The following is a description of a gene set: Genes down-regulated in double positive thymocytes: wildtype versus over-expressing HDAC7 fused with VP16. from publication Kasler HG, Young BD, Mottet D, Lim HW, Collins AM, Olson EN, Verdin E (PMID 21398603) Human Gene Set: GSE26488_WT_VS_VP16_TRANSGENIC_HDAC7_KO_DOUBLE_POSITIVE_THYMOCYTE_DN species: Homo sapiens Abstract of publicaton: CD4/CD8 double-positive (DP) thymocytes express the transcriptional repressor Histone Deacetylase 7 (HDAC7), a class IIa HDAC that is exported from the cell nucleus after T cell receptor (TCR) engagement. Through signal-dependent nuclear export, class IIa HDACs such as HDAC7 mediate signal-dependent changes in gene expression that are important to developmental fate decisions in multiple tissues. We report that HDAC7 is exported from the cell nucleus during positive selection in thymocytes, and regulates genes mediating the coupling between TCR engagement and downstream events that determine cell survival. Thymocytes lacking HDAC7 are inefficiently positively selected due to a severely shortened lifespan and exhibit a truncated repertoire of TCR Jalpha segments. The expression of multiple important mediators and modulators of the response to TCR engagement is altered in HDAC7-deficient thymocytes, resulting in increased tonic MAP kinase activity that contributes to the observed loss of viability. Remarkably, the activity of Protein Kinase D, the kinase that mediates nuclear export of HDAC7 in response to TCR signaling, is also increased in HDAC7-deficient thymocytes, suggesting that HDAC7 nuclear export governs a self-sustaining auto-excitatory loop. These experiments add to the understanding of the life/death decision in thymic T cell development, define a novel function for class IIa HDACs, and point to a novel feed-forward mechanism whereby these molecules regulate their own state and mediate stable developmental transitions. Title of manuscript: Nuclear Export of Histone Deacetylase 7 During Thymic Selection Mediates Immune Self-tolerance. abstract of manuscript: Histone Deacetylase 7 (HDAC7) is a TCR signal-dependent regulator of differentiation that is highly expressed in CD4/CD8 double-positive (DP) thymocytes. Here we examine the effect of blocking TCR-dependent nuclear export of HDAC7 during thymic selection, through expression of a signal-resistant mutant of HDAC7 (HDAC7-delta-P) in thymocytes. We find that HDAC7-delta-P Transgenic thymocytes exhibit a profound block in negative thymic selection, but can still undergo positive selection, resulting in the escape of autoreactive T cells into the periphery. Gene expression profiling reveals a comprehensive suppression of the negative selection-associated gene expression program in DP thymocytes, associated with a defect in the activation of MAP kinase pathways by TCR signals. The consequence of this block in vivo is a lethal autoimmune syndrome involving the exocrine pancreas and other abdominal organs. These experiments establish a novel molecular model of autoimmunity and cast new light on the relationship between thymic selection and immune self-tolerance. Goal of Microarray experiment: We did these experiments to determine how alteration of the function of HDAC7, a site-specific and signal-dependent repressor of transcription, changes gene expression in CD4/CD8 DP thymocytes., and this is the list of marker genes: CYB561A3, ERO1A, GRN, SPNS3, ABHD5 (NCBI Gene Id 51099), CDC42BPB, OBI1, S1PR3, LAX1, MAP2K1, BID, ACKR2, TGFBR1, PDE4D, BZW2, GPR156, PIP4K2A, DTX1, LY96, HCK, NEBL, MYL4, ATF6, RPS4X, PA2G4, SIRPA, TMEM154, NCBP1, CD274, FTO, RPS9, FBXL5, CYP39A1, RXFP1, FCRL5, DPH5, SORBS2, ACKR3, UTRN, ATXN1, RNF145, QDPR, BMP2K, PLAC8, GM2A, CTSC, RPL36A, PLXNC1, RPL24, RPL32, THADA, DUSP16, RPS5, LDLRAD3 (NCBI Gene Id 143458), CACNA1E, HERC3 (NCBI Gene Id 9838), MYOF, SERPINE2, CAPN2, TRPS1, COQ8A, SLC25A4, LY6S, CR2, CD38, TBC1D9, NDST1, DNAJC3, TBL1XR1, MS4A7, SCARNA17, CARMIL1, LYNX1, NAE1, TRIM7, RPL37A, PDE8A, ABR, ST3GAL2, ZMAT4, GNS, MICU3, CYBB, CSF2RB, IL9R, CD300LF, UBE2R2, TAF1D, RPL13, MARCKS, RUNDC3B, ARHGEF12, BCAP29, BLNK, MGAT4A, ROGDI, SRGAP3, ZC3H12D, MTMR1, RPL12, CD9, PIK3R4, BCAR3, PRKACB, CREBL2, SUCO, MYCBP2, CD81, WDR11, PDLIM2, USP11, AATF, HSPA5, BLK, RPL39, TYROBP, EDEM1, DOCK10, PPL, SNORD104, RPL37 (ribosomal protein L37), FOXRED1, RALB, LILRB4, RPL19, MICAL3, S1PR1, EEF1B2 (eukaryotic translation elongation factor 1 beta 2), MACO1, CD36, REPIN1, TRPM2, PLEKHA5, GOLIM4, TERB1, TSGA13, NRP2, NEDD4, PRPS2, PTPRJ, RASGEF1B, TLR3, CYFIP1, RUFY3, PTPN1, SEMA7A, IL1RAP, PRDM9, KLHL6, RPS14, PTPN14, UBE2E2, PDCD2L, PLBD1, BCL7A, PLD4, ORC4, MOCS2, LAIR1, FAM167A, CIBAR1, ZC3H12C, RPS13, FFAR2, HCST, TFDP1, NPM1, PTPN18, TPST2 (tyrosylprotein sulfotransferase 2), GALNT12